The following is a description of a gene set: Oropharyngeal squamous cell carcinoma Human Gene Set: HP_OROPHARYNGEAL_SQUAMOUS_CELL_CARCINOMA A squamous cell carcinoma that originates in the oropharnyx. studied in species Homo sapiens, and this is the list of marker genes: NUTM1, BRD4, STAT1, CDKN2A, DKC1, ATR